The following is a description of a gene set: species: Mus musculus Mouse Gene Set: GOCC_SWI_SNF_COMPLEX A SWI/SNF-type complex that contains 8 to 14 proteins, including both conserved (core) and nonconserved components; contains the ATPase product of the yeast SNF2 or mammalian SMARCA4/BAF190A/BRG1 gene, or an ortholog thereof., and this is the list of marker genes: Dpf2, Smarcd1, Bcl11b, Smarce1, Arid2, Bcl7a, Actb, Phf10, Arid1a, Actl6b, Bcl11a, Actl6a, Smarcd3, Smarcc2, Smarcc1, Smarcd2, Brd9, Pbrm1, Dpf3, Smarca4, Bcl7c, Smarca2, Arid1b, Ss18, Smarcb1 (SWI/SNF related, matrix associated, actin dependent regulator of chromatin, subfamily b, member 1), Bicral, Bicra, Bcl7b